Given this list of marker genes SMARCA2, PHF10, SS18L1, SMARCA4, ARID1B, BCL11B, DPF3, SMARCE1, ACTL6A, SMARCD3, DPF1, ARID1A, BRD9, SMARCC1, DPF2, BICRAL, ACTL6B, SMARCD2 (SWI/SNF related, matrix associated, actin dependent regulator of chromatin, subfamily d, member 2), BCL7C, BRD7, SMARCB1, SS18, PBRM1, ARID2, BICRA, SMARCD1, ACTB, BCL7A, BCL11A, SMARCC2, BCL7B (BAF chromatin remodeling complex subunit BCL7B), here is a description of the gene set: part of: ATP-dependent chromatin remodelers Mammalian SWI/SNF complexes are ATP-dependent chromatin remodellers with a central catalytic ATPase consisting of either SMARCA2 (also known as BRM) or SMARCA4 (BRG1), bromodomain-containing proteins that bind acetylated histones. In addition to SMARCA2/4, SWI/SNF complexes also contain varied organizations of 10-14 other proteins, many of which were initially identified as BAFs (BRM/BRG1 associated factors). This module describes the assembly of three well characterized SWI/SNF complexes, the canonical BAF (cBAF), equivalent to the SWI/SNF complex from S. cerevisiae, the polybromo-containing BAF (pBAF) (equivalent to the RSC complex from S. cerevisiae) and the more recently elucidated non-canonical BAF (ncBAF). All three complexes share catalytic subunits (SMARCA2 or SMARCA4) as well as combinations of 5 other common proteins/protein families (ACTB, ACTL6A/B, BCL7A/B/C, SMARCD1/2/3 and SMARCC1/2) and are additionally distinguished by complex-specific subunits. In addition to these three complexes, other SWI/SNF complexes have been identified that play tissue-, cell- or developmental-specific roles (see for instance, Lessard et al, 2007; Ho,Ronan et al, 2009; Ho, Jothi et al, 2009; Zhang et al, 2014) but fundamentally all are involved in chromatin assembly or remodelling through alterations of histone-DNA contacts. Mutations in components of SWI/SNF complexes are frequent in cancers and other diseases.<br>Cryo-EM, cross-linking and gradient sedimentation have revealed the modular organization of mammalian SWI/SNF complexes. The ATPase module contains most of the catalytic portion of the SMARCA2/4 protein and wraps around the nucleosomal DNA. Closely associated with the catalytic module is a domain consisting of ACTB and ACTL6A/B, as well as SMARCB1 and BCL7 paralogs. A core or base module consisting of the SMARCC dimer and SMARCE1, supplemented by many of the complex-specific subunits, makes contact with the bottom side of the nucleosome. Reactome Pathway: SWI/SNF chromatin remodelers studied in species Homo sapiens